Given this list of marker genes HSD17B2, COL4A6, HCAR2, DHRS3, LGMN, HSD17B14, EPSTI1, ASS1, BCKDHA, CCL20, HMGCS1, SGK1, WASHC3 (WASH complex subunit 3), SOD2, RPS6KA5, SCPEP1, NPL (N-acetylneuraminate pyruvate lyase), VAMP4, EEPD1, FAM110A, AKR1B10, ARAP3, CAT, TMEM116, PHGDH, SLPI (NCBI Gene Id 6590), CD69, HLA-DMB, CXXC5, NHERF1, ACSS2, AFM, FAM117B, RBM4B, HNMT, HCLS1, CYP3A5, SLC38A4, AKR1C4, PLEKHF1, CFH, YBEY, RNF144A, AKR1C2, FNIP2, MYG1, PADI3, FSCN1, KIF18B, LMO4, FHOD3, AKR1B1, AKR1C3, VEGFA, RHBDL3, PRSS8, FRAT2, FAM83A, ONECUT2, TSKU, FAT2, HOXD1, RHOBTB2, PLEKHS1, APOBEC3G, UBE2L6, THBD, HEY1, TOB1, PPIAP80, RPL15P3, LINC01116, ARHGAP25, KYNU, MAL, SETMAR, VWF, MCTP1, NDRG1, IDI1, PRKAG1, TP63, MAPK10, FEZ1, CRACDL (CRACD like), KBTBD11, PLIN4, GUCY1A1, LPAR6, IFITM2, GSDME, UTP18, ASCL2, IMPDH1, IRAK3, NR1H3, MEMO1, PIGP, IFI16, SYBU, STARD5, RAPGEFL1, IFI27, DDIT4, AKAP7, IRX3, FOS, TMEM154, MRFAP1L1, SULT1A2, SRD5A2, ANKRD10, ICAM2, GRB14, NMRK1, ELP4, MMP10, DUOX1, C2CD2, GALK2, IL1RN, MYL6B, CYP4F12, IFI44, FABP6, EFS, KRT13, ANTXR2, PBDC1, TCEAL8, SUMO3, PMCH, FTL, MRPS6, COP1, CHPT1, KCNG1, FCGBP, SGCE, STEAP1, C6orf141, MRPL47, PMPCB, KIT, CFB (NCBI Gene Id 629), DHRS9, MT1A, CAB39L, CDC42EP4, TENT5C, AUTS2, HLA-DMA, IMPA2, LINC01091, CYP4F11, PEG10, CADPS2, ABCA6, TOX-DT, PLA2G4F, CA12, LZTS2, SLC25A23, CYP4B1, IFIT3, GPX2, MTX2, GPNMB, TNFSF10, TBC1D4, ELF5, TSC22D1, ALDH4A1, SESN3, MX1, EGFL6, LCN2, GPRC5C, CLEC2B, SLC27A5, POLE4, CLCA2, ISG15, XDH, XAF1, PMAIP1, GPR15LG, PIGR, FGFBP1, GCNT2, APOL2, SLCO3A1, BHLHE40, NUCKS1, IL23A, RHOV, PARP3, THAP11, WLS, SCNN1A, SDCBP2 (syndecan binding protein 2), SELENOP, ZNF365, FCGRT, ANTXR1, INSIG1, ZG16B, ATP5PF, SLC7A8 (solute carrier family 7 member 8), IFIT1 (NCBI Gene Id 8374), HMGCS2, SMIM19, TNFAIP2, ARHGEF6, NLRP7, PRDX2, DEPP1, S100A8, CASP1, ETV5, VPS41, RGS2, CXCL8, CSTB, BRWD1 (NCBI Gene Id 54146), SBK1, DPY30, NFIB, HLA-DRA, GLDC, TMEM38B, SLC26A6, C17orf49, DYRK1A, ETS2, SMAD6, PLBD1, SNCAIP, ALDH3B2, MX2, KCNK1, SLC2A1, PTMAP4, REPIN1, RGL1, RPS6KA2, CRYZ, DBI, SOCS2, SPRY1, ACSL1, AMACR, NIPSNAP2, PRKCB, MMP7, NT5E, CKB, FTH1P11, BCL11A, ANKRD50, WNT5A, SPRR1A, OAS1, ANXA5 (annexin A5), YAE1, CYP3A7, PIP (prolactin induced protein), C17orf58, MTFP1, LANCL1, IRAG2, APOC1, CD74, CSRP2, C14orf132, ZNF320, CTSC, CRABP2, TESK2, STAT1, ISG20, ALDOC, CXCL10, PRXL2A (peroxiredoxin like 2A), SALL2 (NCBI Gene Id 6297), CCNYL1, DEFB1, WARS2, NLGN4X, IFITM3, NUP88, FAM3B, SSBP2, LAMP3 (lysosomal associated membrane protein 3), RIN2 (NCBI Gene Id 54453), HCAR3, CXCL1, DYNLT2B, PLCB1, FBP1 (NCBI Gene Id 2203), UGDH, C15orf48, PGM1, ABCA9, FAM162A, RAB38, SLX1B, KEL, TMPRSS4, ZIC2, IER3 (NCBI Gene Id 91950), APOBEC3F, SPTSSA, FOXO3, CP, ANXA8, AIM2, INKA1, SORD, MAFB, DEPTOR, MLPH (NCBI Gene Id 79599), MRPS24, PGD, ILDR1, PDCL3, LSS, IRF9, CSTA, TTC3, GATD3, SGPP2, OAS2, FXYD3, AGR2, MBP, BMP2, CAPS, BCL2, CPVL, CDC42EP5, IFI6, IFNGR2, PLXDC2, OAS3, SULT1A3, COLCA1, PLCG2 (phospholipase C gamma 2), C3, CEBPD, RPS4Y2, HOXB2, OVOL2, N6AMT1, LRRC26, FLOT2, PSMG1, GCHFR, PTPRR, GNPDA1, S100A9, PLIN2, KLHDC8B, CEBPA, ZFP36L1, FTH1P8, VAV3, SH3BP1, CCT8P1, C9orf152, PVALB (parvalbumin), MID1IP1, SYT7, TSPAN3 (tetraspanin 3), CUTA, PAMR1, ANG, DYNLRB1, IFI44L, UCP2, IL4I1, SERPINB8, PDE9A, DTX3L, IFI35, ASB9, RTN4, here is a description of the gene set: species: Homo sapiens from publication Jinesh GG, Kamat AM (PMID 28855211) Apoptosis is a process that kills cells. However, cancer stem cells find ways to escape death after commencement of apoptosis. One such mechanism is blebbishield emergency program, in which the apoptotic cancer stem cells first undergo apoptotic body formation but then reassemble apoptotic bodies with main body (nuclei containing) of the apoptotic cells to form spherical to elongated structures called blebbishields. Blebbishields in turn are capable of blebbishield-blebbishield fusion to form transformed stem cell spheres (transformation phase) and then give rise to individual cancer cells from spheres (exit phase). Blebbishields are also capable of fusion with immune cells. The resulting hybrids are called PBSHMS cells in this study. We did microarray analysis of live RT4 cells, and hybrid PBSHMS cells. This data set is a comparison of RT4 cells, and hybrid PBSHMS cells and the gene list includes the genes that are downregulated in blebbishield-immune cells hybrids (PBSHMS). A separate set is provided for upregulated gene list too. Human Gene Set: JINESH_BLEBBISHIELD_TO_IMMUNE_CELL_FUSION_PBSHMS_DN Genes Downregulated in PBSHMS (RT4 blebbishield-to-immune cell fusion)